The following is a description of a gene set: Mouse genes annotated to increased metastatic potential (MP:0001272) retrieved from the Mouse Genome Informatics database via MouseMine from publication Motenko H, Neuhauser SB, O'Keefe M, Richardson JE (PMID 26092688) studied in species Mus musculus Mouse Gene Set: MP_INCREASED_METASTATIC_POTENTIAL, and this is the list of marker genes: E2f1, Il5, Il5ra, Apc, Snai1, Hgf, Rnf19b, Runx1, Braf, Smad3, Npr1, Pten, Pard3, Notch4 (notch 4), Atp6v0a2, Htatip2, Lepr, Myc, Kras, Hic1, Tsc1, Trp53, Ccdc80, Cd226, Itgal, Ifngr1, Lep, Tsc2, Ccn6, Nmi, Setd4, Ifng, Fasl, Msmb, Stk11, Tom1l2, Tnfrsf10b, Cst3, Tpx2, Rb1, Epha2 (Eph receptor A2), Mcm3, Cdkn1a, Ntn4, Hmgn1 (NCBI Gene Id 15312), Cdkn2a, Trim16